The following is a description of a gene set: from publication Min L, Isa SA, Fam WN, Sze SK, Beretta O, Mortellaro A, Ruedl C (PMID 22250091) A simultaneous engagement of different pathogen recognition receptors provides a tailor made adaptive immunity for an efficient defence against distinct pathogens. For example, cross talk of TLR and c-type lectin signalling effectively shapes distinct gene expression patterns by integrating the signals at the level of NF-κB. Here, we extend this principle to a strong synergism between the Dectin-1 agonist, curdlan, and an inflammatory growth factor, GM-CSF. Both together act in synergy in inducing a strong inflammatory signature which converts immature DCs to potent effector DCs. A variety of cytokines (IL-1β, IL-6, TNF-α, IL-2 and IL-12p70), costimulatory molecules (CD80, CD86, CD40 and CD70), chemokines (CxCl1, CxCl2, CxCl3, CCl12, CCl17) as well as receptors and molecules involved in fugal recognition and immunity such as Mincle, Dectin-1, Dectin-2 and Pentraxin 3 are strongly up-regulated in DC treated simultaneously with curdlan and GM-CSF. The synergistic effect of both stimuli resulted in strong IKBα phosphorylation, in its rapid degradation and in enhanced nuclear translocation of all NF-κB subunits. We further identified MAPK ERK, as one possible integration site of both signals, since its phosphorylation was clearly augmented when curdlan was co-applied with GM-CSF. Our data demonstrate that the immunomodulatory activity of curdlan requires an additional signal provided by GM-CSF to successfully initiate a robust β-glucan specific cytokine and chemokine response. The integration of both signals clearly prime and tailor a more effective innate and adaptive response against invading microbes and fungi. studied in species Homo sapiens Genes down-regulated in bone marrow-derived dendritic cells: unstimulated versus CSF2 and low dose of 1,3-beta-D-oligoglucan. Human Gene Set: GSE32986_UNSTIM_VS_GMCSF_AND_CURDLAN_LOWDOSE_STIM_DC_DN, and this is the list of marker genes: FAM171A1, FAM120C, ZBTB40, PYHIN1, MED15, SLAMF6, SLC66A3, EEIG1, AMDHD2, EVL, CTSD, LPXN, PBXIP1, TTC22, XPNPEP3, EHD1, CD84, WNT7A, ZBTB20, CNNM2, ZNF655, EVI2B, ITM2B, BMPR2, TRANK1, PNRC1, PARP3, LAMP1, BRI3, DHRS12, GPR183, FLCN, LEPROTL1, CLN3, RPL34, SUMF1, PCED1A, LGMN, JMY, BPTF, SLC25A45, SLC49A4, CD52, LY9, ABCC10, RUNX2, SLC35C2, CD37, ACVR2A, ZBTB25, MSC, MAP3K7CL, GPR137B, APBB1IP, RPL18, PLAAT4, YAE1, ARSG, PAN2, GZMM, DYRK1B, SENP8, ATP6V0E1, LINC00544, PLCG1, ZNF318, SLC38A10, DOCK9, S100A4, NPC2, MAN2B2, LRRC8C, TTYH2, ARHGAP35, TEPSIN, APBB1, PIK3IP1, SERINC3 (NCBI Gene Id 10955), HPS1, UBASH3B, PEPD, ANXA2R-AS1, FNBP4, ARMC2, KLHL21, MAP3K1, CHST7, RPRD2, KLF12, CNOT6L, CREBRF, ADA2, DCP1B, VMAC, PLCB2, SMIM19, ZAP70, TMEM63A, RPS27, ATG2B, ING4, GPR18, VSIG1, ATXN1, UBAP2L, LAX1, CLSTN1, ZHX2, DPP7, BRAF, CDC14A, SYNE2, RCSD1, SERINC5, CNNM3, DGLUCY, MXD4, CLIC5, RASSF3, ARHGAP45, ZNF76, SLC25A38, BTN3A3, CTSF, ATP6V0D1, HEXA, NIPAL2, SLC35D2, CD6, NFATC3, CTSA, ZFYVE26, RPL13AP20, ABAT, ARRDC2, LINC00649, MAP3K12, EXOC4, SARAF, FCMR, SUN2, UBA7, PLPP6, HGSNAT, PREX1, COMMD6, LRRC8D, EPC1, SGSH, HERPUD2, MFGE8, ASXL2, SMPD1, SLC39A13, RGS14, BLCAP, DLGAP1-AS1, GVINP1, UAP1L1, VAC14, CLCN7, IFT27, IKZF3, CCDC180, NFIA, TBCK, TMEM106B, OLFM2, CTSO, RESF1, TPP1, EPB41, LDLRAP1, ZMAT1, FYB1, KLHL24, CTDSP2, SH3BGRL, CD44, PINK1, RNF135, CYP4V2, AKAP13, TRAM2 (NCBI Gene Id 9697), C16orf54, WWC3, TBCEL, JADE2, CASP4, SMCR8, MARF1, GLMP, PLA2G6, CHD3, SLC38A7, FOXP1, YIPF3, MSX2P1, PARP8, WDR81